Given this list of marker genes Rpia, Mtor, Prps2, Rpe, Pgls, Shpk, Aldob, Mlst8, Acacb, Hsd11b1, Tigar, G6pd2, Taldo1, Rptor, Pgd, Rbks, Prps1, Tkt, Trp53, G6pdx, H6pd (NCBI Gene Id 14379, hexose-6-phosphate dehydrogenase (glucose 1-dehydrogenase)), here is a description of the gene set: Mouse Gene Set: GOBP_PENTOSE_PHOSPHATE_SHUNT species: Mus musculus The metabolic process in which glucose-6-phosphate is oxidized to form carbon dioxide (CO2) and ribulose 5-phosphate, coupled to reduction of NADP+ to NADPH; ribulose 5-P then enters a series of reactions that can yield biosynthetic precursors (ribose-5-phosphate and erythrose-4-phosphate) and glycolytic intermediates (fructose-6-phosphate and glyceraldehyde-3-phosphate).